The following is a description of a gene set: from publication Suryani S, Fulcher DA, Santner-Nanan B, Nanan R, Wong M, Shaw PJ, Gibson J, Williams A, Tangye SG (PMID 19965666) Genes up-regulated in B lymphocytes: naïve versus transitional CR2 high. studied in species Homo sapiens Human Gene Set: GSE17186_NAIVE_VS_CD21HIGH_TRANSITIONAL_BCELL_UP Goals/objectives: to identify various gene expression in B cell subsets derived from human PBMC and cord blood, and this is the list of marker genes: ARHGAP30, DNASE2B, OMA1, IKZF1, ABLIM1, RAB8A (NCBI Gene Id 4218), CFAP54, RHBDD1, ATP5F1E, CTSB, SLCO3A1, RBMS3, SLC30A4, CDPF1, ZNF786, RAP1GAP2, SLC27A4, SERPINE2, ABTB3, MRPS5, RNF222 (NCBI Gene Id 649287), TTC19, ZSWIM1, KCNMB4, PNKP, SLC34A2, HCST, LIME1, SF3B5, DRAP1, F8A1, ITGB5, AIP, CNST, PHF20L1, PPA2, GSC, FAM220A, PMEL, SLC17A7, TMEM14C, CABP4, SWSAP1, LGALS3BP, CLIP1, TRMT2A, DZIP1, VPS16, OXSM, TDRP, CYP11B2, GALNT10, ESM1, ZNF385C, BMP5, FLT3, SLC6A19, ACTN2, PRKACB, POLR3C, AKAP12, RNF39, MOB3B, TRIO, GPD2, TRPS1, CCPG1, ANGPTL4, MOGAT1, TCF7, HECTD1, KCTD13, APH1B, MS4A8, DDIT4, LUZP1, NAGPA, SENP6, LGALS3, DNAAF11, BCL6B, HTRA3, NIPAL1 (NIPA like domain containing 1), CBFA2T2, SNAPC5, TRAPPC3, ALS2CL, TGFBR3, TMEM63B, CDK2AP2, ELANE, CHD7, PFKP, CNEP1R1, ADAT1, CD300LG, RNF168, ZBTB11-AS1, C4orf51, OSCP1, CDCA5, CCNB1IP1, CDH17, TBC1D7, RPL41, STOX1, ILRUN, HS2ST1, KLHL25, DENND2D, PPP1R3C, PRSS16, POU2AF1, LSP1, SEPTIN6, MACROH2A1, LMOD2, IL17RE (interleukin 17 receptor E), GUCA2B, CILP2, CRLF1, HSDL1, PRTN3, ANGPTL3, CFAP43, MARCHF2, SETD4, MSL2, SLC25A30, UBE2U, SERPINB1, HIGD1C, TMT1A, CHST10, OVCA2, TMEM176A, IGFBP4, LMO4, KRT26, MARVELD1, DPEP3, C4orf54, CLIC4, PARP3 (poly(ADP-ribose) polymerase family member 3), TMEM176B, PPP1R37 (protein phosphatase 1 regulatory subunit 37), CCR7, UMODL1, GALNT6, COQ10A, MANBAL (NCBI Gene Id 63905), ARHGDIB, PRPS1, TMEM141, CDH8, BHLHE40, VSIG4, GMFG, AADAC, SCO1, SECTM1, IL18R1, TFB2M, SNAI3, KCND2, APPL2, HAPLN3, PLCG2, BANF1, KYAT1, MOG, LYPD6B, TCF25, KCNS1 (potassium voltage-gated channel modifier subfamily S member 1), MFSD2B, MRPL27, LRRC4B, RAB39B, IL17RC (NCBI Gene Id 84818), RNASEL, ANXA6, MPDU1, SMIM3, KIF5C, XDH, GNPTG, GAB3, PACRG, HEATR5B, FEZ1, PDLIM4, EXOSC2, BUD13, ASCC1, PSTPIP1, STK4, PGAM2, S100A11, FLT3LG, PDE6A